The following is a description of a gene set: studied in species Mus musculus Mouse Gene Set: CUI_MONOCYTE_LIF_RESPONSE_UP from publication Cui A, Huang T, Li S, Ma A, Pérez JL, Sander C, Keskin DB, Wu CJ, Fraenkel E, Hacohen N (PMID 38057668) Cytokines mediate cell-cell communication in the immune system and represent important therapeutic targets. A myriad of studies have highlighted their central role in immune function, yet we lack a global view of the cellular responses of each immune cell type to each cytokine. To address this gap, the authors created the Immune Dictionary, a compendium of single-cell transcriptomic profiles of more than 17 immune cell types in response to each of 86 cytokines (>1,400 cytokine-cell type combinations) in mouse lymph nodes in vivo. A cytokine-centric view of the dictionary revealed that most cytokines induce highly cell-type-specific responses. For example, the inflammatory cytokine interleukin-1β induces distinct gene programmes in almost every cell type. A cell-type-centric view of the dictionary identified more than 66 cytokine-driven cellular polarization states across immune cell types, including previously uncharacterized states such as an interleukin-18-induced polyfunctional natural killer cell state. Genes positively differentially expressed in cell type: Monocyte upon treatment with cytokine: LIF in mouse lymph nodes in vivo., and this is the list of marker genes: Igfbp6, Tgfbi, Gda, Tpd52, Fkbp5, Mydgf, Ifitm2